Given this list of marker genes Paqr4, Plppr4, Cyp2j8, Ltc4s, Ang4, Gal3st2, Pm20d1, Appl2, Hdlbp, Ddx20, Ankrd23, Gstm7, Plcg2, Arsa, Cga, Prox1, Tmx1, Cyp2d10, Hint2, Pex13, Ptgis, Inpp5j, Msmo1, Lipn, Plcd3, Rgn, Star, Selenoi, Th, Ces2a, Gal3st1, Snai1, Sult2a4, St8sia3, Nudt19 (NCBI Gene Id 27945), Crebl2, Cyp4f18, Apod, Aldh3a1, Agk, Cyp46a1, Gprc6a, Peds1, Fgfr4, Atp5f1a, Acsf2, Htr2b, Sptlc1, Gpat2, Erg28, Crat, Ugt2a2, Fmo4, Dhrs7, Fshb, Dhdds, Pbx1, Dgkq, Ugt2b35, Hsd17b4, Aldh1a1, Cyp2c54, Lonp2, Inpp5b, Afp, Acaa1a, Abca8a, Neu4, Apobec1, Idi2l, Zpbp2, Dbi, Bglap2, Pip4p1, Smpd3, Plpp6, Acot3, Cyp2a12, Ncor1, Lipe, Bco2, Sh3glb1, Pld3, Pla2g2e, Sult2a1, Aplp2, Dkkl1, Sf1, Idi1-ps1, Plcd4, Nkx1-1, Pgap4, H6pd, Capn2, Lipo2, Pla2g2a, Plcxd3, Tmem150a, G6pc1, 6430550D23Rik, Acp3, Dgkz (NCBI Gene Id 352984), Lep, Akr7a5, Hycc2 (hyccin PI4KA lipid kinase complex subunit 2), Adra2a, Glyatl3 (NCBI Gene Id 435528), Acer3, Lipg, Rdh16, Mif, Idh1, Pon1 (paraoxonase 1), Flvcr2 (feline leukemia virus subgroup C cellular receptor 2), Asmt, Fmc1, Acad10, Sorl1, Pdgfrb, Casp1, Acoxl, Tlcd3b, Them4, Dkk3, Vps54, Hdhd5, C1qtnf2, Cnr1, Chp1, Gdpd2, Gm8978, Impa2, C1qtnf9, Smpdl3b, Igf2, Glb1, Lsr, Pla2g2c, Fmo5, Crkl (v-crk avian sarcoma virus CT10 oncogene homolog-like), Plcz1, 4930402F06Rik, Aldh3b2, Creb1, Cebpa, Ins2, Pigu, Cyp39a1, Wdtc1 (WD and tetratricopeptide repeats 1), Plb1, Pck1, Agmo, Impa1, Gimap5, Slc37a4, Adgrf1, Pcsk9, Ces2f, Tysnd1, Alox5, Asah2, Sgms2, Ch25h, Far2 (fatty acyl CoA reductase 2), Lpcat2b, Gpr146, Stard4, Acaa2, Mgll, Plin1, Rbp2, Acadm (NCBI Gene Id 99793), Rorc, Pnpla7, Adipor1, Naglu, Schip1, Ilvbl, Ndufs6, Cyp3a41a, Lrp1, Paqr3, Naga, Akr1c12, Pla2g10, Prkaca, Tsku, Mblac2, Aldh1l2, Cyp2j7, Gk5, Aacs, Acsl4, Ugt1a1, Lrp5, Pcyt1a, Gpr82, Med1 (mediator complex subunit 1), Ugt1a9, Kit, Twist1, Lipo4, Cpt1b, Bmncr, Acot9, Plcl2, Pde8b, Ces1f, Sphk1, Cyp2r1, Fgfr1, Slc35c1, Eci1, Pigt, Acsl1, Mmut, Alk, Pigw, Cyp2c50, Cyp2c29, Gpld1, Elovl1, Hsd17b11, Agap2, Pcyt2, Ptges3-ps, Slc30a5, Iah1, Acnat2, Pigq, Mbtps2 (NCBI Gene Id 675926), Scp2 (sterol carrier protein 2, liver), Pdk3, B4galt4, Sts (steroid sulfatase), Ugt2b37, Faxdc2, Hcar1 (hydrocarboxylic acid receptor 1), Ptpn22, Id2, Ppt1, Sult2a7, Abhd6, Ehhadh, Enpp2, Ccdc3, Mup3, Mogat2, Zfp69, St6galnac3 (ST6 (alpha-N-acetyl-neuraminyl-2,3-beta-galactosyl-1,3)-N-acetylgalactosaminide alpha-2,6-sialyltransferase 3, NCBI Gene Id 20447), Degs2, Chkb, Plekha1, Dhrs4, Map7, Osbpl10, Slc16a1, Mecp2, Tm6sf2, Prdx6, Tmem86a, Fabp6, Nsmaf, Foxa2, Mgst3, Pik3r1, Adh7, Acadl, Ogt, App, Kbtbd2, Cyp11b1 (NCBI Gene Id 13071), Lclat1, Gc, Ang, B4galt5, Pip5kl1, Dnajc19, Chka, Disp3 (dispatched RND transporter family member 3), Tbxas1, Nr3c1, Acad8 (NCBI Gene Id 66948), Ptdss2, Tiparp, Atg14, Aig1 (androgen-induced 1), Sptssa, Mup5, Fut4, Lypla1, Lbr, Abhd12, Arf1, Abca7, Lipa, Kat2b, Cyp26a1, Spp1, Atm, Ptges, Cpt1c, Arv1, Ocrl, Plbd1, Samd1, Pdss1, Enpp1, Fdx1, Elovl5, Akr1c14, Cln3, Gpx1, Pigp, B4galt6, Bdh1, B3galnt1, Gzmb, Psap, Mtmr4, Lrcol1, Cyp2a22, Pnpla6, Lipm (NCBI Gene Id 78753), Chrm5, Hnf4a, Ggcx, Cyp2g1, Bckdhb (branched chain ketoacid dehydrogenase E1, beta polypeptide), Naa40, Mtmr1, Acp6, Trex1, Bco1, Gimap6, Pla2g2d, Ces1g, Chpt1, Ces1a, Bglap, Ttc7b, Gpat3, Isx, St3gal4, Lima1, ENSMUSG00000144291, Acsbg1, Cyp2f2, Egr1, Spart, Lactb, Galr2, Blvra, Pik3cd, Ggta1, Rbp1, Cln8, Etfa, Sptssb, Npc1l1, Dgkk, B3galt4, Hacd2, St3gal5 (ST3 beta-galactoside alpha-2,3-sialyltransferase 5), Oc90, Nus1, Cers5, Il6st, Mcat, Ugcg, Angptl3, Tmem38b, Cyp4a10, Fdft1, Vac14, Hsd17b13 (hydroxysteroid (17-beta) dehydrogenase 13), Sdr42e1, Enpp7, Hps1, Thrb, Gdf15, Srebf2, Abcd2, Ces1h, Ormdl1, Acad11, Pla2g15, Pik3c3, Sp1, Abcd3, Scap, Abca4, Acsbg3, Ptgds, Cyp2j13, Hsd3b2, Apobr, Rdh1, Ttr, Inpp5e, Comt, B4galt1, C3, Ang5, Fdps, Atg7, Armc5, Decr2, Pik3r4, Pip5k1a, Sftpb, Dld, Porcn, Cdipt, Hadhb, Mir214, Tnf, Endou, Cyp4f13, Cyp2d22, Htd2, Abcc1, Gdpd3, Smpdl3a, Eif2ak3, Napepld, Dagla, Rnf213, Pparg (NCBI Gene Id 19016), Sgpp1, Echdc3, Slc27a4, Pdgfb, Cyp2j5, Stat5b, Pex2, Pigz, Prkab1, Ndufab1, Adh4, Pgap3, Cyp2s1 (NCBI Gene Id 97376), Hsd17b10, Adora1, Prkaa1, Errfi1, Acot6, Fitm1, Sc5d, Cds1, Gba1, Pla2g4e, Cyp2b10, Dnajc15, Pxmp4, Pigx, Cyp26b1, Pcyt1b (phosphate cytidylyltransferase 1, choline, beta isoform), Akt2, Mtmr6, Fmo2, Mgst2, Cers6, Apoa1, Acad9, Mppe1, Cbr1, Phyh (NCBI Gene Id 98889), Abhd5, Sult1d1, Mtmr3, Ptgs1, Hadh, Pnpla5, Lpcat2, Acbd7, Cyp3a16, Kcnma1, Ggps1, Slc27a6, Lrp2, Rbp4, Plch1, Alox15, Pgap1, Plin5, Rdh8, Fabp5, Sik2, Eci2, Pisd, Lepr, Lpcat4, Dgka, Lpin1, Fig4, Etfdh, Hsd17b2, Bcat1, Lpgat1, Dbil5, Adh6a, Pigl, Cyp4a30b, Mboat7, Acacb, Dgat1, Malrd1, Pdk1, Pafah1b3, Tecrl, Sptlc2, Cyp1a1, Mtor, Daglb, Edn1, St8sia6, Ivd, Elovl6, Mir199a-2, Dhh (desert hedgehog), Ttc39d, Plscr3, Pdk2, Clstn3, Fads1, Pdk4, Ces1b, Pde3b, A4galt, Rictor, Bpnt1, Plcb1, Cox10, Acsl5, Ttc7, Apoc2, Spns2, Efr3b, Nfe2l1, Rdh14, 4930568D16Rik, Pmvk, Cyp21a1, Cyp4f40, Pip5k1c, Ncoa2, Crls1, Atp8b1, Acsbg2, Mapk9, Rarres2, Il1a (NCBI Gene Id 16175), Slc16a11, Acsm5, Pik3cb, Eef1a2, Ppargc1a, Cryl1, Trem2, Them5, Ednrb, Tnfrsf1a, Apoe, Pla2g6, Srd5a3, Plcb2, Cers3 (NCBI Gene Id 74802), Sct, Akr1a1, Ormdl2, Pla2g4b, Cyb5a, Ldlrap1, Insig2, Atp5f1b, Prkar2b, Cyp26c1, Rdh10, Mtmr12, Bloc1s6, Cd74, Acer1, Gykl1, Plcb3, Scly, Sult1e1, Kdsr, Apoc3, Akr1c20, Abca1, Nr1h3, Sirt1, Scnn1b, St6galnac4, Ptpmt1, Aadac, Prdx6b, Atp6v1b1, Ephx1, Pigf, Gdpd4, Gpat4, Alox12e, Ppara, Drd3, Cyp2b19, Gfi1, Sds, Serpina6, Gper1, Abcg1, Akr1c6, Hcar2, B4galnt1, Apoh, Neu1, Cyp2u1, St6galnac1, Pcx, Bmpr1b, Neu3, Ormdl3, Inpp5d, Cyp4x1, St8sia1, Acot2, Plpp5, Lipk, Nr5a2, Ccnc, Bbs1 (NCBI Gene Id 52028), Acat1, Sult2a3, Bckdk, Cubn, Cwh43, Tm7sf2, Rab38, Hpgd, Plppr3, Adh1, Adipoq, Alox8, Acox3, Irs1, Adgrf5, Aldh8a1, Pafah1b2, Acads, Ebp (EBP cholestenol delta-isomerase), Smg1, Gata6, Abcd1, Spata18, Anxa1, Npy1r, Il1b, Psapl1, Adm, Acot12, Plcb4, F2, Cyp2a5, P2rx1, Fabp4 (fatty acid binding protein 4, adipocyte), Cyp2b9 (NCBI Gene Id 13094), Npc1, Slco1a6, Bscl2, Lamp3, Gstp-ps, Lpin3, Xbp1, Fech, Vapa, Bdh2, Idi1, Crem, Echs1, Pla2g3, Pemt, Pip4k2a, Pi4k2a, Glt6d1 (glycosyltransferase 6 domain containing 1), Gstm6, Aldh3b1, Rdh7, Cerkl, Oxct2b, B3galt1, Pyurf, 3110082I17Rik, St3gal6, Ano9, Tnfaip8l3, Fads2, Baat, Fabp2, Aldh1a3, Hnf1a, Abhd8, Plpp1 (phospholipid phosphatase 1), Bmp2, Nceh1, Lpcat3, Ces1c, Pecr, Fads2b, Enpp6, Prkaa2, Insig1, Pigc, Prkce (NCBI Gene Id 98094), Gsta1, Mogat1, Slc45a3, Sccpdh, Cyp2b13, Lcat, 2610005L07Rik, Hsd3b1, Pex5, Cyp2d12, Dhcr7, Ebpl, Rubcnl, Dpm2, Angptl4, Ang6, Cbr4, Dolk, Hsd17b8, Naaa, Abhd4 (NCBI Gene Id 68688), Aqp8, Cers1, Mtmr9, B4galnt2, Pla2g12a, Cyp4a29, Dpm1, Dcaf5, Mtm1 (NCBI Gene Id 56614), Aasdh, Ppard, Acot1, Wnt10b, Htr2a, Serinc2, Zbtb20, Hexb, Abhd15, Pgs1 (phosphatidylglycerophosphate synthase 1), Gcdh, Lipi, Mbtps1, Soat1, Prxl2b, Ttc39b, Asah1, Sult2a8, Gpd1, Fgl1, Egfr, Cyp2j9, Klf9, Gstp1, Ugt2b5, Hacd1, Akr1b1, Dpep1, Decr1, Pik3c2a, Nr1d2, Fut1, Pikfyve, Cacna1h, Adh5, Synj1, St3gal1, Lpl, Cdk8, Pla1a, Akr1c21, Gnpat, Cyp2j11, Plcl1, Avp, Tmem135, Itpkb, Abca8b, G6pd2, Hacd3, Dpep2, Hsd3b3, Pnpla2, Nr1h4, Cyp4a12a, Degs1l, Mapk14, Plcxd1, Slc22a13, Igfbp7, Plch2, Cyp1b1, Alms1, Mfsd2a, Adtrp, Apob, Gm6993, Ugt1a7c, Igf1, Inpp4a, Pip4k2b, Tbl1xr1 (transducin (beta)-like 1X-linked receptor 1), Cyp2w1 (NCBI Gene Id 640150), Acsl3, Sec1, Pgp, Gde1, Inpp1, Serpina12, Tamm41, Dgkb, Liph, Pdss2, Acaca (acetyl-Coenzyme A carboxylase alpha), Mir423, Cerk, Tmem43 (transmembrane protein 43), Stard3, Inhba, Pign, Plpp4, Agps, Ankrd26, Sgms1, Mlxipl, Sphk2, Cyp2d26, Acat2, Cyp2t4 (NCBI Gene Id 384724), Akr1d1, Pigs, Fgf1, Ptdss1, Fuca1 (NCBI Gene Id 78549), Ptgs2, Gpaa1 (GPI anchor attachment protein 1), Gstm2, Coq2, Abca5, Pld6, Ptgr3, Angptl8, Hycc1, Cds2, Prkag2, Cept1, Lhcgr, Adhfe1, Hadha, Fam135a, Mid1ip1, Hmgcll1, Cyp27b1, Cpt2, Jazf1, Ghsr, Gal3st3, Plppr5, Tspo, Nucb2, Ubr4, Oxsm, Lias, Serinc1, Gpx4, Apon, Acsl6, Hmgcs1, Esr1, Cyp8b1, Pank2, Dgke, Pld4, Hpgds, Mcrip2, Fa2h, Hsd11b1, Mtmr11, Pigb, Cd2ap, Pld1, Sod1, Uvrag, Etfbkmt, Qki, Cyb5r3, Mtmr7 (NCBI Gene Id 54384), Pitpnc1, Ech1, Sdsl, Pdgfra, Stat5a, Dab2, St8sia2 (ST8 alpha-N-acetyl-neuraminide alpha-2,8-sialyltransferase 2), St3gal2, Ceacam2 (CEA cell adhesion molecule 2), Fmo1, Cyp4a12b, Slc27a3, Ddhd1, Mtln, Lcn5, Hmgcr, Plcxd2, Cyb5r2, Sco1, Plcg1, Abhd16b, Acadvl, Tyrp1, Proca1, Acbd5, Mlst8 (NCBI Gene Id 70343), Hao2, Cyp7b1, Gstm3, Cyp2c37, Cyp51, Plce1, Lipo1, Pik3c2g, Sdr16c5, Abhd2, Agpat4, Cers2, B3gnt5, Ptprn2, Dpm3, Sirt6, Acss3, Hrh1, Rpe65, Sik1, Sctr, Lrat, Cyp24a1 (cytochrome P450, family 24, subfamily a, polypeptide 1), Htr2c, Smpd5, Rdh12, Crot, Cnep1r1, Scd1, Il4, Oxct1 (3-oxoacid CoA transferase 1), Nkx2-3, Lpcat1, Awat2, Acsf3, Synj2, Cyp2c40, Sult2a5, Cyp3a11, Sel1l, Avpr1a, Acsm3, Sesn2, Ptgr1, Crppa, Lyst, Lipf, Inpp4b, Atg4a, Cln6, Cftr, Ptges2, Plaa, Sirt4, Sqle, Pla2g5, Cert1, Piga, Scarb1, Prkcd, Gdpd5, Cyp4a31, Serac1, Tmem86b, Hsd11b2, Per2, Cel, Agpat5, Htra2, Apoa4, Thnsl2, Plp1, Cyp4f39, Srd5a2, Aldh3a2, B4galt3, Pi4ka, Ces2e, Elovl3, Zmpste24, Crk (NCBI Gene Id 12928), Acsm2, Por, Cyp3a57, Aldh1a7, Itpkc, Prpf19, Rab7, Pik3c2b, Gstm4, Gk2, Rora, Dhrs9, Zfp750, Cyp11a1 (NCBI Gene Id 56432), Bmp6, Lmf1, Ggt5 (NCBI Gene Id 23887), Cygb, Tmem68, Casp7, Thrsp, Ptgr2, Cth, Hexa, Ptprq, Prmt3, Pam, Apoc1, Erlin2, Rptor, Echdc2, Gla, Rdh5, Pla2g4a (NCBI Gene Id 226493), Cyp17a1, Auh, Cmtm2a, Prkag3, Gpihbp1, Cideb, Cyp2j12, Lypla2, Pnpla3, Sirt3, Galc, Ugt2b36, Tcf7l2, Shh, Cyp2c39, Abca3, Erbb4, Lpin2, Etnppl, Elovl4, Pdgfa, Abhd1, Cav3, Igf1r, Cidec, Hao1, Rest, Hsd3b5 (hydroxy-delta-5-steroid dehydrogenase, 3 beta- and steroid delta-isomerase 5), Agt, Aloxe3, Dgki, Pnliprp1, Ces2h, Fads3, Ptpn11, Nfkb1, Obp2a, Ifng, Acbd3, Plpp2, Snca, Tecr, Pmp22, Slc27a1, Smpd4, Abhd16a (NCBI Gene Id 53772), Pla2g1b, Hacd4, Tm9sf2, Amacr, Cpt1a, Saa1, Dgat2, Dhrs11, Alox12b, Agpat2, Sult2a6, Strap, Cyp2j6, Rdh9, Bltp1, Prlh, Cyp7a1, Acnat1, Gpam, Pip5k1b, Mlycd, Acss2, Hsd3b9, Plppr1, Cyp4v3, Nsdhl, Gba2, Bcat2, Asxl3, Smpd2, Fut2 (NCBI Gene Id 14344), Lct, Fkrp, Mlx, Myo5a, Golm1, Ces1d, Pafah1b1, Apof, Ctdnep1, Pigg, St6galnac6, Clpsl2, Becn1, Gip (gastric inhibitory polypeptide), Mvd, Ywhah, Avil, Ip6k3, Cyp27a1, Abhd12b (abhydrolase domain containing 12B), Cyp4a32, Cyp3a59, Dio2, Mapk1, Gstp2, Slc27a2, Etnk2, Eed, Acss1, Pip4p2, Ldlr, Ins1, Cyp3a44, Cyp2e1, Sacm1l, Acox2, Retsat, Cyp3a25, Pigo, Pla2g7, Pgk1, Pigk, Sec14l2, Fads6, Pla2g4f, Cthrc1, Phb2, Plcd1, Degs1, Abca2, Gps2, Pld2, Pigh, Akr1b7, Ephx3, Hsd3b7, Rack1, Umod, Opa3, Nr1h2, Cp, Hps6, Elovl7, Chst10, Fdxr, Sult2b1, Sult4a1, Pi4k2b, Cyp11b2, St3gal3, Tnfsf4, Rdh19, Pigyl, Acsm1, Cyp4f15, Ugt8a, Fgf21, Gpr180, Lss, Cyp4a14, Cers4, Plppr2, Plbd2, Pla2g2f, Dgat2l6, Nr1d1, Ptprv, Fah, Cyp2d11, Wnt4, Prkg1, Scd3, Mup4, Eci3, Gh, Pcca, Hsd17b12, Dhrs3, Inpp5k, Hacl1, Tnxb, Sptlc3, Acot4, Bcl11b, Akt1, Rdh11, Pgap6, Sgpp2, Ugt2b38, Cav1, Prkab2, Ip6k2, Pnpla8, Akr1cl, Idi2, Cyp2d9, Abcd4, Clcn2, Hsd3b6, Gstm1, Fntb, Slc27a5, Mtmr2, Fut9, Nkx2-1, Mup1, Ephx2, Ceacam1, Hsd17b7, Ugt2b1, Edn2, Ccn1, Abca12, Pnlip, Echdc1, St8sia5, Isyna1, Flvcr1, Cyp2b23, Cyp2c55 (NCBI Gene Id 72082), Zfp125, Adh6b, Sirt2, Snai2, Hsd17b1, Sult2a2, Ang2, Mtmr10, Hsd17b6, Gsdmd, A3galt2, Gpcpd1, Fabp3, Mup2, Plaat1, Klhl25, Pigm, Abhd3, Acad12, Bmp5, Adora2b, Apoa5, Erlin1, Atf2, Lipc, Soat2, Gsta3, Stub1, Gimap3 (NCBI Gene Id 83408), Inpp5f (NCBI Gene Id 79372), Agpat1, Serinc4, Pnliprp2, Plscr1, Cyp4f14, Acot8, Dgkg, P2rx7, Hsd3b4, Inpp5a, Atp1a1, Acap1, Agpat3, Mboat1, Prkag1, Ddhd2, Hmgcl, Abhd11, Bbs4, Abcg4, Akr1c18, Trpv1, Kat5, Pgap2, Srd5a1, Cps1, Adipor2, Fut7, Far1, Osbp, Mttp, Cyp2c38, Nudt7, Cyp19a1, Itgb8, Gpr39, Gnai1, Pex7 (peroxisomal biogenesis factor 7), Apoc2l, Plek, Gnb3, Eif6, Ajuba, Scd2, Etnk1, Acer2, Aoah, Hsd3b8 (hydroxy-delta-5-steroid dehydrogenase, 3 beta- and steroid delta-isomerase 8), Faah, G6pdx, Mboat2, Nudt8, Dhrs7b, Neu2, Bpnt2, Ces2c, Mboat4, Ip6k1, Ptges3 (NCBI Gene Id 80424), Pik3ca, Ces2b, Serinc5 (serine incorporator 5), Acot5, Abca17, Fitm2, Gal, Fgf23, Ugt2a1 (NCBI Gene Id 94215, UDP glucuronosyltransferase 2 family, polypeptide A1), Macroh2a1, Pik3r5, Fgf15, Gdpd1, Alkbh7, Pten, Awat1, Irs2, Abo, Acot13, Alox12, Fabp1, Mvk (mevalonate kinase), Rdh13, Pigv, Ucp3 (uncoupling protein 3 (mitochondrial, proton carrier)), Plpp3, Crabp2, Cyp3a13, Rdh16f2, Sh3yl1, St8sia4, Ces2g, Trib3, Acot11, Erfe (erythroferrone), Sdr9c7, Cyp2c23, Pck2 (phosphoenolpyruvate carboxykinase 2 (mitochondrial)), Gk, Pafah2, Fgf7, Smpd1 (NCBI Gene Id 20597), Gstp3, Npc2, Plagl2, Mfsd8, Acox1, Sox9, Crh, Cyp2d34, Thra, Oma1, B3galt2, Cyb5r1, Brca1, Ahr, Apoa2, Abcb11, Pla2g12b, Pla2g4d, Pibf1 (NCBI Gene Id 75821), Fam135b, Rida, Cyp2a4, St6galnac5, Mup11, Alox5ap (arachidonate 5-lipoxygenase activating protein), Tafazzin, Cyp3a41b, Cat (catalase), Plaat3, Ipmk, Scd4, Akr1c13, Gm2a, Dctn6, Acaa1b (acetyl-Coenzyme A acyltransferase 1B), Il1rn, Mecr, Pik3cg, Pdpn, Lrp10, Slc25a17, Nr0b1, Cidea, Dpagt1, Srebf1, Sorbs1, Slc22a4, Aldh1a2, Fasn, Lipo3, Akr1c19, Plaat5, Acly, Acot7, Dgkd, Cyp1a2, Oxct2a, Sult1a1, Acsm4, Pip4k2c, Prf1, Olah, Gm2044, Dhcr24, Vldlr, Clps, Hmgcs2, Ces1e, Bax (BCL2-associated X protein), Acadsb, Pctp, Crtc3, Gbgt1, Elovl2 (NCBI Gene Id 54326), Hsd17b3, Pnpla1, Abcc9, Cbr1b, Dgkh, Samd8, Itpka, Pla2g4c, Aspg, B3galt5, Etfb, Sgpl1, Nphp3, Hsd17b14, Pi4kb, Tpk1, Inppl1, Aox1, here is a description of the gene set: species: Mus musculus The chemical reactions and pathways involving lipids, compounds soluble in an organic solvent but not, or sparingly, in an aqueous solvent. Includes fatty acids; neutral fats, other fatty-acid esters, and soaps; long-chain (fatty) alcohols and waxes; sphingoids and other long-chain bases; glycolipids, phospholipids and sphingolipids; and carotenes, polyprenols, sterols, terpenes and other isoprenoids. Mouse Gene Set: GOBP_LIPID_METABOLIC_PROCESS